Given this list of marker genes Ecm1, Cd81, Il18, Rara, Tnfsf4, Stat6, Irf1, Il4, Hlx, Ifnb1, Prkcz, Socs5, Anxa1, Clcf1, Nod2, Zfp35, Arg2, Il4ra, Cd74, Ndfip1, Arg1, Il33 (interleukin 33, NCBI Gene Id 77125), Bcl6, Ido1, Il27ra, Ccr2, Xcl1, Dennd1b, Rsad2, Nlrp3 (NLR family, pyrin domain containing 3), Tbx21, Il6, Ascl2, Gata3, here is a description of the gene set: Mouse Gene Set: GOBP_REGULATION_OF_TYPE_2_IMMUNE_RESPONSE studied in species Mus musculus Any process that modulates the frequency, rate, or extent of a type 2 immune response.